The following is a description of a gene set: Abnormal corneal endothelium morphology species: Homo sapiens Abnormality of the corneal endothelium, that is, the single layer of cells on the inner surface of the cornea. Human Gene Set: HP_ABNORMAL_CORNEAL_ENDOTHELIUM_MORPHOLOGY, and this is the list of marker genes: FAS, RPE65, MYOC, ZEB1, VSX1, SPATA7, FOXE3, OVOL2, PITX2, LTBP2, PTPN22, SLC4A11, PAX6, CYP1B1, LCA5, KCNJ13, LRAT, COL8A2, TEK, AGBL1, GRHL2, FOXC1, TCF4